The following is a description of a gene set: from publication Yevshin I, Sharipov R, Kolmykov S, Kondrakhin Y, Kolpakov F (PMID 30445619) Mouse Gene Set: RCOR1_TARGET_GENES studied in species Mus musculus Genes containing one or more binding sites for (Rcor1) in their promoter regions (TSS -1000,+100 bp) as identified by GTRD version 20.06 ChIP-seq harmonization., and this is the list of marker genes: Farsa, 4930412M03Rik, 2610024D14Rik, Vangl1, Mknk1, Rps6ka3, BC065397, Slc30a10, Spry1, Adam17, Polr3gl, Lrrc41, Itpripl1, Sdf4, Limd2, Gm6686, Kifap3, Ccnd3, Pvt1, Dnajb5, Pou2f1, Aqp8, 4930580E04Rik, Il9r, Ptges3, Ap1b1, Gm23723, Entrep3 (endosomal transmembrane epsin interactor 3), Cyb5r3, Ermap, Cic, Sec22b, Sebox, Erv3, Naa15, Gm5069, Zfp846, Ercc3, Sh3glb1, Amz2, Atg16l2, Ube2g1, Plekha1, Septin1, Trappc14, Ppp4c, Snhg12, Wdr37, Vps45, Septin6, Mrpl38, Lrpap1, Zfp91, Ppif, Cln8, Fbxw4, Senp3, Psme4, Pigo, 3010003L21Rik, Osbpl9, Stx16, Llgl2 (LLGL2 scribble cell polarity complex component), Tbc1d1, Nlrp1b, Gm21909, Rnft2, Eif4e2, Nup35, Gm12301, Yes1, Trim80, Nudt19, Il1bos, Tm2d2, Appl2, Sptb, Lmo2, Ufl1, Mff, Vsir, Arhgap18, Pla2g4c, Trmt13, Prelid2, H2bc4, Cmah, Trim46, Fgd1, Tomm40l, Prrc2c, Dock8, Ndor1, Zeb2os, Gata1, Mc5r, Gm24233, Rpl31, Clcn2 (NCBI Gene Id 404589), Gm9964, Gm14882, Cryba4, Hook2, Mir7-1, Knstrn, Rab37, Mapk6, Lrig1, Zbp1, Rrm1, Smdt1, Kcnq1, Arhgap27, Tom1l1 (target of myb1-like 1 (chicken)), Spink4, Serpinb9b, Pklr, Lima1, Clcn3, Ttc39d, Mettl16, Dmwd, Glo1, Nprl3, Mmp27, Rbm19, 5430420F09Rik, Zfp541, Gm24016, Mir30a, Ppfibp2, Gm16198, Gm10603, Furin, Farp2, Tiprl, Rnps1, Tyrobp, Osbpl11, Lgals9, Il1r2, Cysltr1, Mysm1, Dgkz, Cdk9, Spag6, Hacd4, Zfand4, Ank3, Itga2b, Gm14513, Ccdc174, Nfya, Fancc, Chek2, Cd40, Lmnb2, Tsen54, Ddx19a, Gm11412, Yae1d1, Tbl1x, H1f2, Fbxo38 (F-box protein 38), Stat5a, Prdm1, Patz1, Erich1, I830077J02Rik, Rcsd1, Gm17308, Aknad1, Cpa1, Ssbp3, Txnip, Srpk2, Brwd3, Mrps36-ps2, Relt, Tal1, Dusp13b, H4c3, Plaur, Slc37a3, Ptpn2, Tmem161b, Hdac6, Scarb1, 4933431K14Rik, Gm28513, Spata45, Spta1, Taf4, Tbc1d8 (NCBI Gene Id 54610), Slc4a1, Ubap2l, Gm7467, Gm9568, Ndufb5, Rgs12, Asb3, Fcer1a, Adrm1, Ppm1m, Akap7, Usp31, Fmo5, Aurkaip1, Nexn, Pcyox1l, Gm13830, Kdm2b, Zfyve16, Cstf2t, Isca1, Styk1, Creb1, Trnt1, Gadd45a, Zfp68, Syngr1, Zfp275 (zinc finger protein 275), Siglech, Plpp1, Ccng2, Rdm1, Ptger4, Tmem131, 4933433G15Rik, Slc40a1, Arl4d, Parn, 2010110E17Rik, Chpf2, Prkcsh, Mettl3, Ripor1, Cxxc1, Gm24992, Zbtb24, Tsc1, Pip4p1, Gm16531, Chil5, Qsox1, Vat1, Otud7b, Stc2, Cfap126, Rin3, Cfap97d1, Wincr1, Odf2l, Flvcr1, Gpatch1, Tbc1d22b, Atp13a3, Trpv2, Psma6, H4c8, Limk2, Mir6369, Gm7266, Gm14862, Gm17954, Arhgef10l, Gar1, Manbal, Glipr1, Ccdc63, Slc17a4, Napsa, Vezt, 4933431E20Rik, H4c6, Zeb2, Snora61, Pnpla6, Tdg-ps2, Nkapl, C3ar1, I830134H01Rik, Slc2a3, Fam120a, Prnd, 4930558K02Rik, Txndc11, S2bpcox16, Mycbp2, Plppr2, Cacnb3, Gm15848, Tnfrsf13b, Tspan8, Slc1a5, Samsn1 (SAM domain, SH3 domain and nuclear localization signals, 1), Usp22, Dmac1, Pkd1l2, Srrm2, Tpm3, Cenpl, Tor1b, Gpn2, Psen2, Fyb1, Morf4l2, Cep85, Bbs4, Car2, Slc2a9, Gm12607, Gm11713, Klhl18, Caskin2, Apobr, Exosc2, Prkcz, C2cd3 (NCBI Gene Id 277939), Gfi1b, Poldip3, Nlrp3, Alg13, Sphk1, Coro2a, Gm10143, Fbxo31, Pak4, 1700063H04Rik, Tnks2, Mknk2, Zfp316, Ccdc12, Psmd5, Kif16b, Nr3c1, Cyba, 4931413K12Rik (NCBI Gene Id 73468), Hacd3, S100a4, Il13, Pigv, 1810064F22Rik, Cdca7, Mia3, Gm15983, Mt1, Muc1, Trip13, Slc25a21, Ptch1, Fam117a, Sting1, Ankrd13a, Art4 (NCBI Gene Id 68257), A230107N01Rik, Polr2g, Hcar2, Naglu, Col15a1, Ero1a, Pde6a, Zdhhc17, Xpo1, Gm2a, Cyp4x1os, D030056L22Rik, Orai3, Gm9936, Zbtb6, Sipa1l3, Nrip1 (NCBI Gene Id 77882), Smim3, Gadd45g, Ogfrl1, Rgl1, Abcb4, Gm15263, Gm15938, Hyal2, Iqsec1, Nt5dc3, Plgrkt, Selenos, Zfp882, Prkab1, D830032E09Rik, Bptf, Rnf166, Uqcc1, Myo1f, Cox10, Gcnt2, Snx12, Usp3, Ctdsp2, Apcs, Gm28857, B2m, Pemt, Gm5464, A430005L14Rik, Usf1, Polr1b, 9530068E07Rik, Clec12a, 5730403I07Rik, Fam149b, Shcbp1l, Ddx51, Tars1, Evi5, 4930402F06Rik, Egf, Zbtb5, Hycc1, Hpn, Mtap, Pgap6, Treml4, Sumf2, 2310010J17Rik, Gm26740, Ppp1cb, Siae, Ttc33, Snora44 (NCBI Gene Id 100217418), Tespa1, Aoc1, Tbce, Emg1, Efcab8, Naa25, Gm26108, Mboat7, Otos, Sec14l1 (SEC14-like lipid binding 1), Gm10840, Cyth3, Srr, Fbxl17, Itgb7, Tmigd3, Ubb, Adam33, Sema4d, Rhag, Stab1, Mmd, Ralgps2, Ccdc71, Nfic, Gm23206, Ccdc186, Sdccag8 (NCBI Gene Id 76816), Slc43a2, Api5, Ksr1, Rap1a, Nsa2, Gm26427, Ebp, N4bp2os, Prdm15, Gm11696, Synj2bp, Mon2, Scrn3, Csde1, Rabep2, Hat1, Trf, Chst15, Camk1d, Ctu2, Cnot6l, Alox5ap, Smim15, Sfi1, Gid8, Bri3bp, Rpl28, Slfn9, Pdk2, Slx4ip (NCBI Gene Id 97467), Gtf3c6, Akap13, Ctdsp1, Itm2b, Dusp2, Ttyh3, Gm24607, Mlkl, Tor1a, Pde4b, Gm7158, Gm16008, Mrpl33, Gm11175, Rps6ka1, Arpc5l, Dnaja1, Rnu7, Irak2, Bola3, Crem, Pttg1ip, Akt1s1, Pbx4, Ythdf2, Rnf215, Sgpl1, Cbfa2t3, Sec24d, Fam169a, H4c9, Tasl, Gm5842, Fam110a, Gm16754, Vcf2, Rbbp7, Rem2, Inmt (indolethylamine N-methyltransferase), Fli1, Nmnat2, Nsfl1c, Sanbr, Disp2, Zfyve26, Asb1, Gm17967, Cxcr5, Slc17a1, Rabgef1, Cyp2w1, Asxl2, Nt5m, Gm23664, Pank1, Fxyd5, Rabepk, Napepld, Ssbp2, Myh10, Flcn, Slc39a11, Gm12061, Ints8, Rabgap1l, Mta2, Hsd17b11, Dennd2d, Eef1a1, Nudt1, Prg3, Ube2l6, Appl1, Scoc, Golt1b, Yipf4, Gm25723, Prx (NCBI Gene Id 233019), Fbxo21, Ly96, Gm2479, Gm12950, Fa2h, Zfp1, Tbc1d14, Tmem109, Mbnl1, Ift88 (NCBI Gene Id 21821), Gm16322, Morn2, Tonsl, Sowaha, Herc1, Ttc5, Slx9, Gm11805, Tsen34, Oit3 (oncoprotein induced transcript 3), Rcc1l, Ptprc (protein tyrosine phosphatase receptor type C), Snx29, Prkrip1, Prdx2, Pafah1b3, Tmem242, Clec2d, Rab43, Srd5a3, Gm13547, Prxl2c, Slc38a5, Zfp148, Gart, Cnot6, Gm11622, Rab11a, Psmc3ip, Cnr2, Foxk2, 4921531C22Rik, Noa1, Ss18l2, Snrnp35, Poll, Pikfyve, Dpagt1, Gm8066, Aox1, Samd13, Gpr146, Dgkd, Ebna1bp2, Sla, Flywch1 (FLYWCH-type zinc finger 1), Mir6541, Tmeff2, Fcgr2b, Slc12a6, Add2, Zfp646, Mir5110, Sptan1, Nicn1, Gm13748, Rbm48, Ndst2, Shfl, Icam1, Yjefn3, Npm1 (NCBI Gene Id 18148), Xrn2, Clec4d (NCBI Gene Id 17474), Fes, Rasal1, Cbfb, N4bp1, Dusp19 (NCBI Gene Id 96977), Ddx56, Gm16894, Rapgef6, Tmx1, Fam13b, 4930540M05Rik, Havcr2, Gm8969, Ccm2, Fgd6 (NCBI Gene Id 13998), Nf1, Gm5447, Lsp1, Gls, Chn1, 4930403D09Rik, Dars2, Cln3, Mcmbp, Itpa (NCBI Gene Id 99201), Il33, Parl, Pick1, Specc1, Dhrs7, Pira12, Phf21a, Chmp1b2 (NCBI Gene Id 74520), Cd200r4, Trap1, Gm15407, Trim56, Slc12a4, Jmjd1c, Chd2, Atp8a2, Kdm2a, Gstm1, Son, Cda, Msh6, Hemk1, Psma4, Msto1, Hoga1, Dusp16, Nrg4, Mcrs1, Ptges3l, Hdac4, Xiap, Spmap2, Gm10384, 3300005D01Rik, Spi1, Szrd1, Mpzl2, Dmap1, Usp53, Nfkbia, Lmbr1l, Acp2, Gm13531, Clock, Gm26225, Sgta, Ttll13, Exoc3, Atad1, Tep1, Gm24046, Ippk, Exosc4 (NCBI Gene Id 76326), A930018P22Rik (NCBI Gene Id 68243), A430027C01Rik, Akr1b1, Zbtb21, Alg9, Snx8, Mrpl48, Prkacb, Smad6, H1f5, Gm11520, Ankrd63, Ankrd37, Cuedc2, Dennd4b, E130116L18Rik (RIKEN cDNA E130116L18 gene), Celf3, Pigq, Ubash3b, Igsf8, Tigar, Gm6077, Zfp821, Celf6, E230029C05Rik, Tnfrsf23, Trp53i13 (NCBI Gene Id 67875), 1700125G22Rik, Dock11, Cks2, Adora3, Sbf1, Anp32e (acidic nuclear phosphoprotein 32 family member E), Tnfaip8 (NCBI Gene Id 106869), Tmem65, Gm5475, Kbtbd4, Gm25921, Gm15328, Abcc1, Prdx1, Ces2g, Ndufa3, Zfp668, 1700009J07Rik, Ubap1, Cdk20, A730036I17Rik, Lrrc66, Anxa2, Ccdc88b, Rhot1, Clec16a, Itpk1, Sdf2l1, Gm16253, Nlgn3, Mcpt2, Frmd8os, Pcbp4, Depdc1b, Asf1b, Mir7650, Zfp672, Popdc2, Epn1, Mir7036b, Ttpal, Ppp2r3a, Gm13783, Ppp1r15b, Wdr19, Ccdc115, Tcirg1, Klf1, Map4, Gm23454, Rnaseh2a, Trim11, Dnaja4, Cntrl (NCBI Gene Id 98835), Slc52a3, C1s1, Tnfrsf22, Ankk1, Ppp2r2d, Tent5d, Panx3, Gm22353, Ppfia1, Brd1, Polr2k, Ehd3, Mir8112, Ttc23l, Adgrg5, Lhfpl2, Cep120, Syt11, Rnf24, Eya3, A930009A15Rik, Gm26766, Gtf2a2, Arhgef18, Hsdl2, Gm14869, Pkm, Arrb1, Slirp, Aqp10-ps, Dgkg, Atad2b, Gm16731, Cd82, Hsp90b1, H2bc6, Bhlhe41, Rsrp1, Gm26018, Snrnp27 (NCBI Gene Id 66618), Xpnpep1, A930019D19Rik, Ddit4, Zmiz1, Gm9967, Fiz1, Pak1ip1, Gm11532, Smarca2 (SWI/SNF related, matrix associated, actin dependent regulator of chromatin, subfamily a, member 2), Fetub, Il16, Pctp, Abt1, Pdia4 (protein disulfide isomerase associated 4), Gm24041, Mrpl1, Parp3, Myb, Daam1, Cyrib, Trpm5, Apobec1, Psat1, Nuggc, Prcp, Gm36307, Vcl, Morc4, Rgs18, Slc17a5, Jmy, Gpr35, Gm14965, Pcyt1b, Mblac2, Tgif1, Cfh, Gcnt1, Gm13427, Cd68, Ptp4a1, Prepl, AU019990 (NCBI Gene Id 767814), Eef1akmt1, Pcgf5, Peli1, Gm49316, Bnip2, Txndc15 (thioredoxin domain containing 15), Rps20, Phkb, 4930467K11Rik, Gngt2, Zfp62, Gm13033, Dhx8, Alyref2, Gm19060, Cables2, Gm14453, Prkag2, Mdn1, Vps37b, Nrxn1, Sh3kbp1, Tfeb, Egr1, Mrpl20, Dpcd (deleted in primary ciliary dyskinesia), Map4k3, Gm17977, Srsf10, Zhx3, Arhgef33, Klhl20, Mtmr12, Il6, Aldh3b1, Ifnlr1, Gm8013, Ggt1, Ghdc, Ago1, Meis1, Khdc4, Cpeb3, H4c16, Exoc2, Tssk6, Eif2b3, Noc4l, Gm19708, Rrp1, Gm5547, Gm20627, Prdm9, Ttc7, Psmb2, Dpep2, Platr4, Mzt1, Selenoh, Oscar, 1700034H15Rik, Spata17, Sec24a, Itgb1, Cpa3, Car12, Chid1, Snx11, Prdm10, Txndc12, Ndrg3, Trerf1, Mirt1, Gm2453, Dock10, Parvb, BC030343, Abi3, Zfp638, Trappc2b, Spring1, Smim12, Gm6283, Tbl1xr1 (NCBI Gene Id 99912), Git2, H4c4, Add1, Btf3l4, Cul4a, Hpgds, Gm9939, Slc25a25, Nipsnap2, Eps15, Slc5a10, Timeless, Gse1, Ngrn, Camkmt, Isg20, Atp6v1h, Hfe, Slc7a5, Gnas, Rpl7l1, Gm28535, Syp, Rph3a, Spns2, Pdk3, Lypla2, Gbp7, Tmem229b, Snora16a (small nucleolar RNA, H/ACA box 16A), Arih2, Top3b, Clca3a1, Tlr6, B4galt7, Morrbid (NCBI Gene Id 100048565), Psmb5 (NCBI Gene Id 19173), Hmbox1, A930007I19Rik, Tmem263, Rundc1, 1110059E24Rik, Slc23a2, Mief2, Tmem253, Nvl, Gm11936, Fryl, Xpo6, Vcpkmt, Poglut1, Gm16120, Sec23ip, Rfx7, Klhdc8b (kelch domain containing 8B), Pax6, Ddias, Atp5f1a, Cyp17a1 (NCBI Gene Id 13074), Asic4, Samd10, Acyp2, 4833418N02Rik, Gm13423, Pdcd4, Fkbp1a (FK506 binding protein 1a), 2900052L18Rik, Il4, Srsf7, Plxnc1, Clec4a2, Zfp292 (NCBI Gene Id 77306), Mpnd, Gm38331, Slc22a3, Suclg1, Nepn, Ift57, H2bc18, Atosb, Dsc2, Dctn6, Odad1, Czib, Gm13571, Tln1, Abi1, Kifc5b, Mir6398, Tsg101, Zfp27, Ank1, Upf2, Csf2rb2, Kat2b, Cela3b, Gm10644, Slc33a1, Rara, Epor, Trim16, Gm12107, Uspl1 (NCBI Gene Id 231915), Fam98b, Mgat1, 2310058D17Rik, St7, Cep55, Svbp, Cyth1, Lix1, Ppox, Gm11471, Mrps22, Krt88, Pla2g1b, Ing4 (NCBI Gene Id 28019), Rbm6, Erlec1, Gypc, Znhit3, Tmem219, Unc13d, Ccdc159, Psme3, Itpr3, Cfap20, Ago3, Rffl (ring finger and FYVE like domain containing protein), Arel1 (apoptosis resistant E3 ubiquitin protein ligase 1), Znhit1, Alkbh1, Tmem86b (transmembrane protein 86B, NCBI Gene Id 68255), Igkv10-95, Zbtb11, Gnat2, Abat, Usp54, Dpf1, Mia2, Pdk1, F730311O21Rik, Iba57, Ttc8, Ankrd13c, Exoc1, Fntb, Nlrp6, Dennd2c, Fam187a, Phactr1, Diaph1 (NCBI Gene Id 28110), Xbp1 (NCBI Gene Id 52219), Abhd17b, Malsu1, Gm12443, 2700049A03Rik, Calcoco1, Atrnl1, Ube2e3, C1ra, Capza2, Slfn14, Dhtkd1, Zscan12, D830025C05Rik, Rpl15-ps4, Jrkl, Dnajc5g, Gm25657, Slc25a23, Tlcd1, Syngap1 (synaptic Ras GTPase activating protein 1 homolog (rat)), Mtfr1, Mpzl1, Pfdn4, Shoc1, Ahcyl2, Syt2, Togaram2, Zftraf1 (zinc finger TRAF type containing 1), P2ry14, B230217C12Rik, Nans, Eif3h, C3, Kat7, Kalrn, Micall2, Atp6v0a1, Cdc123, Pomk, Pigc (NCBI Gene Id 98680), Ldha, Add3 (NCBI Gene Id 98171), Rnf212, Bcl3, Il10rb, BC028471, Mir5128, Dnajc19, Tmem101, Rcn1, Septin9, Oxsr1 (oxidative-stress responsive 1), Grb2, Wdr93, Elmo2, Atp2c1, Gm8087, Niban3, Tex9, Chmp5, Steap3, Gm13470, Cdc42, Zfp516, Ech1, Gm13262, Asxl1, Mir707, Gm24844, Nfam1, Mcts1, Pik3r6, Mtmr9, Kel, Ezh2, Vpreb1a, Dok2, Hdac7, Necap1, Ell3, Cdk19os, Gm14100, Fyco1, Ftdc2, Tmem156, Dync1i2, Slc39a13, Tmem97, Tspan32, Rc3h2, Comtd1, Eogt, Slc4a2, Gpatch8, Pstk, Cmtr1, H2ac12, Zfp26, Gm9920, Tulp4, Ints1, Adcy6, Lpin2, Wdr24, Phb2, Prex1, Odad4, Cntnap1, Atf7ip (activating transcription factor 7 interacting protein), Tm9sf3, Polr3a, Zc3h3, 5730460C07Rik, Anapc16, Vps35l, Neat1, Dcun1d5, Map7d1, Gm17399, n-R5s41, Alpl, Mogs (mannosyl-oligosaccharide glucosidase), Ptov1, Oxa1l, Smpd5, Dock4, Gm14017, Zfp563 (zinc finger protein 563), 4933426K07Rik, Tgfbr3, Nt5c3 (5'-nucleotidase, cytosolic III), Tnfrsf14, Cd300lf, Lrrfip2, 2310011J03Rik, Efcab2, Pgm2, Gm15742, Sgk1, Crisp1, Mrgpra9, Irf2bpl, Tnks1bp1, Akna, Tnnt1 (troponin T1, skeletal, slow), Zfp623, Arl6ip1, Rps12-ps19, Birc6, Sfmbt1, Snord3a, Exd2, Ackr1, Pfdn1, Rab11fip4os1, Sgk3, Cdc42se1, Nek6, Mir700, Pgap3, Gm8888, 2410004B18Rik, Gdpd5, Gm12708 (NCBI Gene Id 105244624), Gm13842, Creg1, Ash1l, Mcm2, Fam193b (NCBI Gene Id 212483, family with sequence similarity 193, member B), Rpl34, Slc26a11, Tg, Dusp12, Btnl10, Aldh3a2, Ift46, Srgap2, Klhl6, Zmynd8, A230056P14Rik, Fcrl1, E130215H24Rik, Zfp512, Acly, Atp7a, Rbm41, Zfp617, Ptpa, Mcm5, Cmc1, Ndst3, Znfx1, Scrn2, Gm12472, Cd1d1, Marchf5, Prkd3, AI839979, Fas (NCBI Gene Id 14102), Nfat5, Aldh4a1, Cdk5rap2, Colec11, Zcchc2, Spag9 (sperm associated antigen 9), Ankrd48, A430034D21Rik, Dgki, Cltb, Npdc1, Megf9, Csf2rb, Rlbp1, Rhoh, Zzz3, Stat3, Slc4a10, Arhgap15, Blvrb, Stab2, Actn3, 4930439D14Rik, Samd8, Atp8a1, Aktip, Ehd1, Cd81, Rrp9, Pacsin2, Il1rl1, Cacna1s, Grep1, Mettl4-ps1, Itpkb, Chaserr, Nagpa, Rsrc2, Gin1, Nelfa, Snd1, Rps19bp1, Gm29332, Nupr1, Slc41a3, Abhd15, Mrpl16 (NCBI Gene Id 94063), 1700054O19Rik, Uba7, Dtx3, Rps6kc1, Fcgr1, Nasp, Ckap4, Actb, Gm15493, Ift20, Itsn1, Gm37125, Lemd2, Ssr2, D330041H03Rik, Hap1, Hemgn, 2700097O09Rik, Arhgef12, Med7, Gm10699, Soat1, Gm3945, Cep70, Gm5258, Mat2b, Slc7a1, Elovl5, Gm14881, 8030453O22Rik, Pkig, Gm34086, Tspyl3, Tsga10, Smurf1, Gm17952, Madd, Tm9sf4, Zkscan17 (NCBI Gene Id 268417), Rpl10-ps2, Nek7, Mrpl52, Mvb12a, Arhgap25, Fbxl12, Gm7626, Atp5f1b, Mfsd4a, Cir1, Dbil5, Tpgs1, Kifc2, Sft2d1rt, Bbs5, Gm4734, Pik3cg, Bms1, Rheb, Eif3l, Emid1, Mlip, B9d2, Klhl15, Pym1, Larp4, Ica1, Cyp4f13, Ccrl2, Tinf2, Atp5pf, Ccm2l, Pofut1, Tnfaip2, A330023F24Rik, Tha1, Kdm4d, Qser1, Tmem203, Gnb3, Selplg, Taf1a, Bag1, Psap, Paqr7, 1700028I16Rik, Ccdc124, Tnip3, Golga7, Gm5558, Ptpn12 (protein tyrosine phosphatase, non-receptor type 12), Ypel3, Mgat5, Ndel1, Shld1, Trim14, Gm26513, Spink10, Susd3, Asphd1, Bcl9, Arhgef11, Gm11335, Bank1, Mir7671, Kif7, Ccdc167, Ubc, Timm17a, Tbpl1, Nek8, Anp32a, Kmo, Mrpl21, Slc25a46, 2810001G20Rik, Ppa1, Gm15408, Ctse, Ncoa6, Tbc1d17, Gapdh, Rnf185, Pheta2, Gm16316, Rars1, Cish, Cux1, Rgs19, Acox3, Hsp90aa1, Nfe2l1, Gp5, Cep250, Abcg4, Mir5123, Ttll6, Ccdc138, Romo1, Ccz1, Lrig2, Wnk4, Gm10371, Gtf2e2, Hmgb2, Kank2 (KN motif and ankyrin repeat domains 2), Imp4, Gm23042 (predicted gene, 23042), Ptdss2, Rpf1, Phlda2, Kat6a, Stx12, Ovca2, Gypa, Atad5 (NCBI Gene Id 319895), Smg6, Pnisr, Uqcrh, 4931422A03Rik, Ryr1, Cep164, Asap1, Atg2b, Rnf44, Creld2, Marchf8, Mogat2, Ralgapa2, Cdc14b, Prr13, Acbd4, Map1lc3b, Calr, Vamp4, Gnai3, Amotl1, Taok3, Srp72, Gskip, Clca4b, Hdc, Tomm22, Upp1, Mfsd13a, Fuca1, Rnf121, Ak1, Ndufa13, Washc4, Traf3ip2, 1700021F02Rik, Ddb2, Acsl6, Map3k2, Dynll1, Inhca, Ikzf2, Nkpd1, Atxn2, Wipf1, Gcat, Gm29487, Grn, Pdxk, Sdsl, Pigz, Gm10433, Gm43380 (NCBI Gene Id 115490149), Alg3, Grap2, Mcph1, Bhlhe40, Cox7a1, Avil, Vps25, Nr1h3, Ubl3, Septin8, Gpr18, Aida, Rbks, Picalm, Egfl7, Dstyk, Taf13, Birc5, Gm10053, Pigu (phosphatidylinositol glycan anchor biosynthesis, class U), Rpl6l, Nox1, Wfdc21, Rad51b, Poc5, Napa, Stap1 (NCBI Gene Id 56792), Mef2c, Zfp287, Dmxl1, Setdb1 (SET domain, bifurcated 1), Tmc4, Dpy19l4, 1700066J03Rik, Arhgap30, Nme4, Aldh1b1, Cbl, Odad3, Aff3, Gne, Cfp, Btaf1, Ndfip1, Sema4a, Urad, Mir7647, Hnrnpf, Mterf4, Necap2, Vmn1r4, Abcc3, Zbtb18, Cst3, Cyp4f16, Prkx, Recql5, Dync2h1, Gm7785, Tnfrsf8, Znrf3, Zfp655, Phf8, Ube2o, Hmbs, Gm9889, 1700113A16Rik, Cyp4b1-ps2, Mttp, Gm19774 (predicted gene, 19774), Tff1, Id3, Uros, Cdkn2a, Diablo, R3hcc1l, Mir5100, 1700064M15Rik, Naif1, Slc29a1, Gm11551, Batf3, Car1, Mkks, Xpnpep2, Pkd1l3, Cacna1c, Ecd, Mrtfa, Hexa, C1galt1, Cd200r3, Abl1, Bod1, Prr14, Fer1l5, Surf6, Nfkbie, Gsdmd, Gm11398, Crtc3, Cand2, Grcc10, Dnajc10, Zfp524, Gm16069, Clns1a, Gm10086, Denr, Lsm6, Ighmbp2 (NCBI Gene Id 20589), Gm14945, Cdc42bpa, Ddc, Mob3c, Nck2, Rab21 (NCBI Gene Id 216344), Synj2, Ankrd35, Cspp1 (NCBI Gene Id 72327), Adnp, Gm27252, Ifrd2, Gm18856, Vwa5a, Nfkbiz, Plec, Ece2, Gm25402, Pik3ca, Cd180, Frrs1, Sp2, Prkcq, Hacd2, Tmcc2, 4930505N22Rik, Gpr174, Ctnnb1, Ankrd55, 2310033P09Rik, Lgmn, Cdr2l, Plekhg3, Ankrd40, Adamts3, Ndufs2, Rbp2, Dhdh, Camsap2, Osm, Tmbim1, Pex6, Nfs1, Tcp11l2 (NCBI Gene Id 216198), Tfrc, Rnf135, Gm23143, Gng7, Gmfb, Exoc7, Strn, Mylk3, Mif4gd, Slc34a3 (NCBI Gene Id 99048), Nrxn2, Fermt3, Mrps31, Degs1, Ap5s1, Zfp106 (zinc finger protein 106), Rgs9, Nhp2, Esf1, Rab7, Amfr, 9530082P21Rik, Rasgrp4, Zcchc9, 9830144P21Rik, Cd274, Zfp53, Mrgpre, Rpl37, Mir7050, 9430069I07Rik, 8430429K09Rik, Adam11, Pgk1, Tfr2, Nup205, Spr, Dennd10 (DENN domain containing 10), Sh3bp5l, Rasgrp2, Hivep1, Recql, Snx21, Entpd5, Pigt, Mcam, Tent2, Gm17669, Mettl6, Il1b, Lcp1, H4c12, Oprd1, Calm3, Tm6sf2, Spire2, Cd59b, Gdf9 (growth differentiation factor 9), Golph3l, Lsmem1, Fibp, Rnu7-ps1, Atic, Bnip3l, Spns3, Rpl13a, Tti2, Snapc1, Plvap, Hbp1 (high mobility group box transcription factor 1), Stil, Mrpl39, Mir223hg, Crat, Nfe2, Adap1, Gfm2, E2f8, Nip7, Clca3a2, Ehbp1 (EH domain binding protein 1), Aff4, Ier5, 6530401F13Rik, Alg12, Icam2, Zfyve27, Ap2m1, Mgst2, Ywhaz, Vmp1, Sde2, Zfp598, 1700008J07Rik, Art5, 4930519G04Rik, A930028O11Rik (RIKEN cDNA A930028O11 gene), Lmna, Cdc16, Cyb5b, 4930537H20Rik, Pcbp3, Man2a2, Gm28035, Cradd, Eaf1, Gm7666, Aurka, Ppp2cb, Nsun4, Aqp9, Pon3, Eef2k, Glud1, Serf2, Rps21, 2210408F21Rik, Nucb1, Pafah2, Vrk2, Nav2, Ccdc59, Mrnip, Psip1, Tgif1-ps (NCBI Gene Id 669823), Gm9103, Fam3b, Usp45, Slc38a6, Sp100, Zc3hav1, Tdrd9, Mexis, Gm15628, Piwil4, Pfkm, Slc28a2, Mir3091, Spg21, Zfp710, 4930590L14Rik, Adgre4, Slmap, Gabpa, Il7, Tmem150b, Slco5a1, Mindy2, Cttnbp2, Zpr1, Ptk2, Ssc4d, Rpusd2, Rad52, Rab40c, Ubl5, Tmem39a, Dcaf11, Spryd4, Supt16, Vegfd, Sez6l2, Zfp740 (zinc finger protein 740), Uckl1os, Alpk1 (NCBI Gene Id 71481, alpha-kinase 1), Acad12, Dusp3, Psmd11, Fnbp4, Gpbar1, Zdhhc24, Usf3, Rassf1, Tmem243, Papola, Piga, Wiz, As3mt (arsenite methyltransferase), Junb, Redrum, Tlr9, Eftud2, Ptpn9, Prkce, Gm24670, Rcbtb2, D930020B18Rik, S100a3, Myo18a, Thap4, Idh1 (NCBI Gene Id 98427), Espnl, Pcdh1, Cd53, Ttc9b, Cwc15, Exoc5, Gbp3, Utp6, Gm5420, Btbd2 (NCBI Gene Id 83963), Hk1, Pdia2, Caml, E130102H24Rik, Dedd, Dip2a, Uck2, Arf1, Wdr77, Lrrc59, Txndc5, Pcnx1, Uqcrq, AW011738, Mical1, Cebpg, Shb, 1700028K03Rik, Armc7, Pik3r1, Rubcnl, Dhfr, Mir155 (NCBI Gene Id 387173), Sucnr1, Crisp2, Sh2d3c, Uprt, Gm26608, Cog8, D630024D03Rik, Hsp90ab1, Cers2, Gm33280, Thyn1, Gm26590, Cops7b, Gm30648, Cfap57, Or7h8 (olfactory receptor family 7 subfamily H member 8), Rad23a, Cpox, Scamp2, Gm6209, Gal3st2b (NCBI Gene Id 100041596)